The following is a description of a gene set: Aerobic respiration and respiratory electron transport species: Mus musculus Mouse Gene Set: REACTOME_AEROBIC_RESPIRATION_AND_RESPIRATORY_ELECTRON_TRANSPORT, and this is the list of marker genes: Dmac2l, Ndufb6, Adhfe1, Atp5f1e, Mdh1, Pcx, Pdha2, Maea, Ndufa10, Surf1, Ndufb1, Ucp1, Cox19, Sco2, Etfb, Rab5if, Slc25a4, Suclg2, Ndufs5, Uqcr10, Timm21, Ttc19, Cox7a2l, Ndufb7, Hccs, Cox7b, Ndufb8, Atp5pd, Isca1, Ogdh, Sdhd, Uqcrh, Atp5po, mt-Nd3, Ndufv3, Sirt3, Pdk3, Slc25a11, Ndufa9, Higd2a, Higd1a, Pm20d1, Ldhal6b, Ndufaf3, Tmem177, Sdhaf4, Sdhaf1, Me1, Lyrm4, Got2, Ranbp9, Ndufaf5, Ndufv1, Nek1, Fh1, Sucla2, mt-Co2, Fahd1, Pdp1, Slc25a22, Slc25a12, Dmac2, Atp5pf, Rps27a, Ndufa8, Ndufab1, Pdk4 (NCBI Gene Id 27273), Ndufaf6, Pdhx, Tmem186, Glo1, Acat1 (acetyl-Coenzyme A acetyltransferase 1), Nfs1, Hspa9, Armc8, Gpt, Ndufaf8, Ndufs2, Pdhb, mt-Cytb, Cox7c, Dld, Lyrm7, Ndufa4, Dlst, Uqcrq, Atp5mg, Etfdh, Coq10a, Trap1, Cox18, Atp5f1b, Pdpr, Ndufs3, mt-Co1, Coa3 (cytochrome C oxidase assembly factor 3), Atp5mf, Pkm, Cox6b2, Pdp2, Dlat, Ucp3, Cox7a1, Gm10053, Nubpl, Timmdc1, Ndufa6, Cox6a2, Rmnd5a, Cox16, Sdha, mt-Nd4, Slc25a14, Ndufb2 (NADH:ubiquinone oxidoreductase subunit B2), Atp5me, Ndufs7, Ndufc2, Sdhaf3, Idh3a (NCBI Gene Id 76300), Uba52rt, Tmem126b, Ndufaf4, Atp5pb, Hscb, Ndufb11, Ndufs4 (NCBI Gene Id 77728), Ndufb4, Sirt4, Atp5mk (NCBI Gene Id 66477), Gid4, Ndufc1, Ndufa2, Atp5mj, Etfa, Cox8c, Uqcrb, mt-Atp6, Mdh2 (malate dehydrogenase 2, NAD (mitochondrial)), mt-Nd2, Cox6b1, Ubc, Cyc1, Iscu, Cs, Cox14, mt-Nd6, Ndufb5, Ndufs8, Ndufs1, Ldhb, Idh3b, Ndufb10, Ecsit, Uqcrc1, Ndufa12, Atp5f1c, Sdhb, Wdr26, Lyrm2, Cox5a, Gstz1, Atp5mc1, Cox20, Coa5, mt-Co3, Cox5b, Pdk2, Cox15, Slc25a18, Cox6a1, Ldha, Cox4i1, Pyurf, Sco1, Acad9, Me3, Sdhc, Dmac1, Ndufa13, Cox6c, Ndufb9, Pdha1, Vdac1, Mrps36, Atp5f1a, Ndufaf1, D2hgdh, Pgam5, Ndufaf2, mt-Nd1, Isca2 (iron-sulfur cluster assembly 2), Ndufaf7, Slc25a27, Cox8a, Sdhaf2, Ndufv2, Suclg1, mt-Atp8, mt-Nd5, Ucp2, Got1 (glutamic-oxaloacetic transaminase 1, soluble), Fxn, Coq10b, L2hgdh, Rmnd5b, Ndufb3, Cox7a2, Ndufa1, Mkln1, Cmc1, Uqcrc2, Cox4i2, Ndufa7, Higd1c, Pdk1, Ubb, Cycs, Atp5mc3, Uba52, Cox17, Smim20, Nnt, Gid8, Me2, Idh3g, Atp5mc2, Ndufs6, Ldhc, Idh2, Hagh (hydroxyacyl glutathione hydrolase), Ndufa11, Slc25a13, Aco2, Ndufa5, Cox11, Ndufa3, Uqcrfs1, Atp5f1d